Given this list of marker genes TOMM7, TOMM6, TOMM22, TOMM5, TOMM20, TOMM40, TOMM70, here is a description of the gene set: species: Homo sapiens Human Gene Set: GOCC_TOM_COMPLEX A large mitochondrial outer membrane translocase complex that mediates transport of proteins into mitochondrial compartments. TOM transports beta-barrel precursors across the outer membrane and the sorting and assembly machinery (SAM complex) inserts them into the target membrane.